The following is a description of a gene set: Reactome Pathway: PKA-mediated phosphorylation of CREB part of: Calmodulin induced events studied in species Homo sapiens Cyclic adenosine 3',5'-monophosphate (cAMP) induces gene transcription through activation of cAMP-dependent protein kinase (PKA), and subsequent phosphorylation of the transcription factor cAMP response element-binding protein, CREB, at serine-133., and this is the list of marker genes: CALM1, PRKAR1A, ADCY1, ADCY5, NBEA, ADCY2, ADCY4, PRKAR1B, ADCY6, PRKX, PRKAR2A, ADCY3, ADCY9, PRKAR2B, ADCY7, PRKACA, PRKACB, PRKACG, CREB1, ADCY8